The following is a description of a gene set: studied in species Homo sapiens The aim of this study was to quantify the impact of chimeric Foxp3-GFP protein on the Treg cell transcriptional program. Human Gene Set: GSE37605_FOXP3_FUSION_GFP_VS_IRES_GFP_TREG_C57BL6_DN Genes down-regulated in T reg (FOXP3+) cells from B6 mice: Foxp3-Fusion-GFP versus Foxp3-ires-GFP. from publication Darce J, Rudra D, Li L, Nishio J, Cipolletta D, Rudensky AY, Mathis D, Benoist C (PMID 22579475), and this is the list of marker genes: MYLIP, OGN, RMI1, PRKACB, DPEP1, ADAMTS1, HS3ST3A1, ECM1, SNORA21, UPK1B, TDRD7, PRKRA, WWC2, HSD17B4, CDADC1, LIFR, B3GALT2, ADGRG2, MAN2B1, CACNA2D1, DUSP6, ACTN1, CD93, FKBP9, TNFSF18, USP12, TM4SF1, KALRN, ATP8A1, ORMDL1, TENT5A, GGPS1, CCDC80, C19orf38 (chromosome 19 open reading frame 38), CECR2, DSE, MAPK14, ECM2, USP21, MIR20A, IL18, CSMD3, ANGPTL7, H2AJ, KLHL24, HSPB1, CAMK1D, CCL24, SNORA2C, FEZ2, SULT1A1, ARHGAP29, ADAMTS9, CLPX (NCBI Gene Id 10845), ADGRL3, MAGI2, LRRC58, ADAMTS5, IGFBP6, ATF3, PGGT1B, CYYR1, AGL, LOX, TOB1 (transducer of ERBB2, 1), RASL11B, CASK, SERPINB2, PPP2R3A, IFIT1, CRK, GAS6, RASAL2, STARD8 (NCBI Gene Id 9754), RB1CC1, MYO9A, EIF1, GPR141, FKBP7, EHBP1, INPP5A, SNTB2, PF4, PAM, PAPOLA, PDE5A, TOPORS, DUSP5, H2AC6, CTDSP1, CBFA2T2, SRPX, FBLN5, NBEAL1, MAP4K3, RAC1, LATS2, MYO1B, ARHGAP35, SLC25A25, CRYBA1 (NCBI Gene Id 8146), OCRL, MGP, DYNC1LI2, TMEM119, GAS1, FBXO33, IL1RL2, SLC22A5, DLL1, EGFLAM, SLC39A10, BAMBI, GNAI1, SNORD73A, SGK1, PRKD1, VASN, PDK4, ARHGEF10, RCAN1, KLRK1, ARHGEF33, C1GALT1C1, ULK2 (NCBI Gene Id 9706), IFIT3, IL12RB2, SAT2, GZMA, OARD1 (NCBI Gene Id 221443), SLC9A9, TNS1, UBE4A, FBXO32, GRIA3, GBP3, AASDHPPT, JAM3, MPRIP, QSER1, PDE1A, PURG, PRAM1, CDH8, TEAD1, AKAP12, ALOX12, SPA17, RAVER2, MIR145, MNAT1, AGTRAP, TAGLN, F2R, CNKSR3, ID3, ABCA1, SNX7, DDX50, ACSS2, FMO2, RND3, STX17, LRRC32, GNG11, XPR1, SPARC, PCDHB14, ANXA1, CLEC14A, GGT5, KLRC2, UBTD1, FHL1, THBS1, MOSMO